Given this list of marker genes BSCL2, LMNA, PLAGL1, ESCO2, INSR, AGPAT2, HYMAI, KAT6B, here is a description of the gene set: Labial hypertrophy Human Gene Set: HP_LABIAL_HYPERTROPHY studied in species Homo sapiens